The following is a description of a gene set: studied in species Homo sapiens Nocturnal hypoventilation An abnormal reduction in alveolar ventilation occurring during sleep. This is characterized by a rise in arterial carbon dioxide. Human Gene Set: HP_NOCTURNAL_HYPOVENTILATION, and this is the list of marker genes: COL12A1, MYH7, ACTA1, NEB, SELENON, SLC52A3, KLHL41, COL6A1, HNRNPK, TPM2, DNAJB4, CFL2, TTN, FKRP, PHOX2B (NCBI Gene Id 8929), LMOD3